The following is a description of a gene set: from publication Chen Y, Wang X (PMID 31504780) studied in species Homo sapiens Human Gene Set: MIR5089_3P Genes predicted to be targets of miRBase v22 microRNA hsa-miR-5089-3p in miRDB v6.0 with MirTarget v4 prediction scores > 80 (high confidence targets)., and this is the list of marker genes: ARMC10, MAPKAP1, AHSA2P, ITM2B, LHFPL1, BRD1, ATF2, ZFPM2, SLCO6A1, SH3RF1, CLCF1, GOLGA3, CNOT6, PEPD, SLC25A40, CLEC1A, FUCA2, LRRIQ3, GVQW3, MARK3, CYCS, ANKRD13A, CACNA2D1, JCHAIN, HNRNPR, ABCB5, CUL5 (NCBI Gene Id 8065), PELI1, PTPN13, FGF9, PTPN1, GLB1L2, GTPBP10, CFAP119, ZNF704, YTHDF3, CDH2, FRK, VASH1 (NCBI Gene Id 22846), ELMOD2, GRID2, FHIP2A, MYO6, SBK1, NCOR1, SNAP25, GALNT1, PDLIM5, PPP4R3B, CTTNBP2, RGS6, FBXO45, LMNTD1, MYOZ2, NOX4, HRNR, NDST3, FNDC3A, SPOCK3, AIDA, TMEM169, RNF145, CDIN1, SMC6, KIF1B, CPEB2, HMBOX1, PPP1CB, SELENOI, PAPOLG